The following is a description of a gene set: from publication Szanto A, Balint BL, Nagy ZS, Barta E, Dezso B, Pap A, Szeles L, Poliska S, Oros M, Evans RM, Barak Y, Schwabe J, Nagy L (PMID 21093321) studied in species Homo sapiens Human CD14 positive monocytes were purified from healthy volunteers’ blood and cultured in vitro for 4, 12, 24, 72 hours. While culturing, macrophages were activated alternatively with interleukin-4 (IL-4 100 ng/ml) or classically with interferon-gamma (IFNg 100 ng/ml)+tumor necrosis factor (TNF 50 ng/ml) or left without activation. Simultaneously, macrophages were also treated with vehicle (DMSO:ethanol) or 1mM synthetic PPARg agonist, Rosiglitazone. We used Affymetrix microarrays (U133Plus 2.0) to analyze activation and PPARg-induced gene expression changes. Genes up-regulated in macrophages (12h): IFNG and TNF versus rosiglitazone. Human Gene Set: GSE16385_IFNG_TNF_VS_ROSIGLITAZONE_STIM_MACROPHAGE_UP, and this is the list of marker genes: OTUD3, PDCD7, HMGN4, PYGO2, CCDC142, BHMT2, NPHS2, COG1 (NCBI Gene Id 9382), CHRDL2, RPL11, STARD5, LINC00630, CKS2, SERBP1, AOC2, FAM226B, PTPRA, GSDMD (NCBI Gene Id 79792), ENY2, DVL1, CDKN2D, TNFRSF10D, B3GALT2, BRAP, ERLEC1P1, FPR2, CXCR2, CACNA1G-AS1, EP400, MLF1, TMEM272, IKBIP, CRB1, NXNL1, SIPA1L1, AMER3, U2AF2, UPK3B, NEDD9, LINC00710, AAR2, TCHP, NFYA, MSL2, ZNF17, PRR3, PCDHGA11, RAB2B, SCN2B, TFEB (NCBI Gene Id 7942), PBDC1, MRFAP1L1, LINC00582, PSMA1, ELP5 (NCBI Gene Id 23587), CNOT4, PSTK, NACA2, PIGU, LINC02901, CDC37L1, PAFAH1B1, ABCB1, STEEP1, PPP2R2A, HTR1B, SIK3, ZNF155, TTLL11, SGSM3, RBM15, ATIC, FAM76B, CX3CR1, AUTS2, BUB3, PIGH, RPL23AP53, SRSF2, PAPOLA, OR7E87P, ZNF271P, ORMDL2, TUBGCP4, UBE2G2, CHD2, STK35, ACTL6B, FNBP4, DVL3, ANKRD35, PRPF18, ZNF586, MED10, DNA2, IMPDH1, APBA1, CHD1, LINC02582, LARP4, NDUFA4L2, PAPOLG, SIRPG, ZNF516, TESMIN, MED21, METTL1, JADE1, TTI2, ANLN, NKD2, HNRNPUL1, PLK1, LINC01532, SYCE3, ZNF565, SAP30BP, CDC42BPB, ACTL9, GRID1-AS1, ZNF318, ADCY10, SELP, OTOF, FAM236A, ATP2C2, MRPL52, PPA2, TRAPPC13, LPAR4, EEF1A1, TMEM11, NCOA5, DCBLD2, ZNF398, RAB11B, RBM42, TFG, HNRNPU, VWF (von Willebrand factor), SPSB3, FRAT2, KCND3, PTGDR, PSMC4, ZNF165 (NCBI Gene Id 7718), ITPRIPL2, PER3P1, CLIP2 (CAP-Gly domain containing linker protein 2), ZNF254, FCRLA, C15orf40, DBF4, EML6, NSUN4, FGB, LRRC8E, CSNK1G1, GTF2I, ZMYM1, DDX31, HMHB1, FAM227B (family with sequence similarity 227 member B), COL5A2, CMTM5 (CKLF like MARVEL transmembrane domain containing 5), LSM12 (NCBI Gene Id 124801), CCSER1, PAPSS1, CTPS2, ANKRD39, DMRTB1, SLC16A3, INTS15, SLC39A1, PIK3R4, NOL4L, LRRC37A4P, THAP1, NSD1, FAM200A (NCBI Gene Id 221786), GLS, FANCM, SRSF10, DIO1 (iodothyronine deiodinase 1), TSHZ3, LINC02860